Given this list of marker genes LGR4, ZNHIT1, PLA2G2A, PLA2G10, TMEM63B, LPCAT3, NOD2, here is a description of the gene set: Human Gene Set: GOBP_INTESTINAL_STEM_CELL_HOMEOSTASIS Any biological process involved in the maintenance of the steady-state number of intestinal stem cells within a population of cells. species: Homo sapiens